Given this list of marker genes SNX12, HOOK3, SORL1, PTPN23, SNF8, CHMP3, SNX3, MAPK1, STX8, MTMR2, EZR, RDX, DAB2, RAB7A, PIK3R4, RAB11FIP3, FHIP1B, VPS11, WDR81, MAP2K1, DNAJC13, MSN, WDR91, RAB11A, CORO1A, SRC (SRC proto-oncogene, non-receptor tyrosine kinase), MYO1D, AKTIP, RAB5A, WASH3P, MAPK3, EEA1, SNX16, DYNC1LI1, NF2, ANKRD27, KIF16B, EMP2, HOOK1, LMTK2, RILP, PIK3C3 (phosphatidylinositol 3-kinase catalytic subunit type 3), ATG14, BECN1, RAB21, DENND10, MAP2K2, HOOK2, here is a description of the gene set: species: Homo sapiens A cellular transport process in which transported substances are moved in membrane-bounded vesicles between endosomal compartments, e.g, between early endosome and sorting endosome. Human Gene Set: GOBP_VESICLE_MEDIATED_TRANSPORT_BETWEEN_ENDOSOMAL_COMPARTMENTS